The following is a description of a gene set: Reactome Pathway: Purine ribonucleoside monophosphate biosynthesis part of: Nucleotide biosynthesis species: Mus musculus electronically inferred by orthology from the curated human pathway This event has been computationally inferred from an event that has been demonstrated in another species.<p>The inference is based on the homology mapping from PANTHER. Briefly, reactions for which all involved PhysicalEntities (in input, output and catalyst) have a mapped orthologue/paralogue (for complexes at least 75% of components must have a mapping) are inferred to the other species., and this is the list of marker genes: Adss1, Gmps, Impdh2, Adsl, Pfas, Paics, Gart